The following is a description of a gene set: Human Gene Set: PID_KIT_PATHWAY Signaling events mediated by Stem cell factor receptor (c-Kit) studied in species Homo sapiens from publication Schaefer CF, Anthony K, Krupa S, Buchoff J, Day M, Hannay T, Buetow KH (PMID 18832364), and this is the list of marker genes: MATK, GRB2, STAT5A, EPO, GRAP2, SH2B3, SOS1, PDPK1, HRAS, PIK3CA, BCL2, MAPK8, STAP1, GAB1, RAF1, MITF, JAK2, SOCS1, FER, PIK3C2B (NCBI Gene Id 5287), EPOR, SNAI2, SPRED1, KITLG, SHC1, PTPRO, PTPN6, LYN (NCBI Gene Id 4067), SH2B2, PTPN11, CREBBP, STAT3, PTEN, VAV1, SPRED2, CBL, KIT, AKT1 (NCBI Gene Id 207), STAT1, TEC, CRKL (CRK like proto-oncogene, adaptor protein), MAP4K1, FOXO3, GSK3B (glycogen synthase kinase 3 beta), RPS6KB1, MAPK3, MAP2K1, BAD, MAP2K2, PIK3R1, DOK1, GRB10